Given this list of marker genes ENSG00000285884, ANKRD30BP3, ANXA8L1, LINC02632, HMGB1P50, UQCRHP3, RSU1P2, MAPK6P6, ZNF239, ZNF32-AS1, PABPC1P8, ZNF33B, CTSLP4, SPRING1P1, CSGALNACT2, RHEBP1, FAM25EP, C10orf71-AS1, BEND3P1, LINC00839, FAM170B, FAM170B-AS1, MIR3156-1, MARCHF8, RPL35AP24 (NCBI Gene Id 100271631), ENSG00000295267, RPS6P14, PTPN20CP, RNU6ATAC11P, GDF2, ZNF37BP, SYT15, CAP1P2 (CAP1 pseudogene 2), PARGP1, ZFAND4, EIF3LP2, HNRNPA1P33, ENSG00000231964, DUSP8P1, LINC03089, ELOCP30 (NCBI Gene Id 106481670), AGAP14P, MIX23P2, AGAP6, DUXAP3, CXCL12, LINC02623, FRMPD2B, RASSF4, GLUD1P2, ZNF32, C10orf71, HNRNPA3P1, FAM25BP, ENSG00000291065, VSTM4, KSR1P1, ALOX5, CUBNP1, MIR5100, RNA5SP312, RN7SL453P (NCBI Gene Id 106481046), MAPK8, FAM25G, TMEM72-AS1, LINC01264, LINC00841, ASAH2B, ZNF487, RPL23AP61, SYT15B, LRRC18, EIF2AP4, ANKRD54P1 (ankyrin repeat domain 54 pseudogene 1), TIMM23B, OR13A1, COX7BP6, LINC00840, C10orf53, SYT15-AS1, PRKG1 (NCBI Gene Id 5592), BMS1, AGAP9, SNORA74C-1, RPL35AP23, TMEM72, RNU6-885P, AGAP10P, AGAP12P (NCBI Gene Id 414224), LINC01518, FXYD4, FAM21FP, LINC02658, VN1R54P, WASHC2A, CTSLP3, ZNF32-AS3, HNRNPF (heterogeneous nuclear ribonucleoprotein F), FAM21EP, SHLD2P1, ZNF485, LINC02916, RNA5SP317, PGGT1BP1, BMS1P2, NPY4R, MSMB, RPL21P89, WASHC2C, RASGEF1A, RET (NCBI Gene Id 5979), LINC02637, GPRIN2, RNA5SP311, DRGX, FAM245B, CEP164P1, PTPN20, CSGALNACT2-DT, RNU7-193P, ENSG00000229227, CCNYL2, ERCC6, LINC02675, CTSLP2, MIR4294, RPS19P7, TMEM273, SLC9A3P3, RBP3, BMS1P7, OR6D1P, WDFY4, RPL9P21, DYNC1I2P1, LINC03029, PARG, SHLD2P3, TIMM23B-AGAP6, SGMS1, ZNF22-AS1, RN7SL248P, ANTXRLP1, ENSG00000223502, A1CF, SNORA74C-2, CUBNP3, OGDHL, RNA5SP310, FXYD6P1, FAM25C, SLC18A3, ARHGAP22-IT1, IGKV1OR10-1, SLC9A3P1, SHQ1P1, NCOA4, RNU6-1170P, NPY4R2, ANXA8, RNU6-1207P, FRMPD2, RPL13AP19, ZNF22, ANTXRL, AGAP7P, AGAP4, CHAT, SGMS1-AS1, RNU7-107P, ASAH2, LINC00842, CUBNP2, AGAP13P, NUTM2HP, RSU1P1, SNORD3J, RNA5SP315, BMS1P1, ENSG00000309880, LINC02659, RHEBP2, ARHGAP22, TIMM23, DEPP1, LINC02881, DUXAP4, GDF10, ENSG00000305167, ZNF488, RPL21P88, LINC02633, here is a description of the gene set: studied in species Homo sapiens Human Gene Set: chr10q11